Given this list of marker genes APOA2, LRP1, LPL, APOA1, LIPC, SCARB1, VLDLR, LCAT, APOA4, PLTP, APOE, CETP, LDLR, here is a description of the gene set: Familial hyperlipidemia type 3 studied in species Homo sapiens Human Gene Set: WP_FAMILIAL_HYPERLIPIDEMIA_TYPE_3